Given this list of marker genes Abcc3, Adora1 (adenosine A1 receptor), Slc35d3, Ralbp1, Shoc2, Slc25a54, Abcc2, Abcb1a (ATP-binding cassette, sub-family B member 1A), Abcc4, Lrrc8b, Slc35b4, Slc25a19, Cln3, Slc37a4, Slc35a3, Slc25a25, P2rx7, Calhm1, Scarb1, Slc15a3, Vldlr, Slc5a2, Slc35c2, Slc28a3, Cd47, Slc25a24, Slc50a1, Slc29a1, Slc35d1, Slc46a2, Calhm4, Slc29a3 (solute carrier family 29 (nucleoside transporters), member 3), Guk1, Mfsd2a, Slc35c1, Rft1, Lrrc8d, Adcy10, Calhm6, Slc35b3, Slc35b2, Lrrc8a, Slc25a42, Slc29a2, Slc28a2, Pla2g10, Slc15a2, Slc35d2, Abcc5, Slc29a4, Slc25a17, Slc25a4, Slc19a1, Slc25a26, Slc25a31, Slc5a1, Slc28a2b, Slc25a41, G6pc3, Slc37a1, Spns1, Tmem241, Calhm3, Slc35a1 (NCBI Gene Id 99967, solute carrier family 35 (CMP-sialic acid transporter), member 1), G6pc1, Lrrc8c, Abcc6, Ank, Gjb1 (NCBI Gene Id 236927), Slc25a23, Calhm2, Pltp, Calhm5, Gja1, Slc25a5, Slc15a4, Slc17a9, Slc28a1, Panx1, Slc35a5, Slc37a2, Slc10a7, Slc35a2, Lrrc8e, Slc35b1, Abcg1, Lbp, Psap, Plekha8, here is a description of the gene set: The directed movement of a carbohydrate derivative into, out of or within a cell, or between cells, by means of some agent such as a transporter or pore. studied in species Mus musculus Mouse Gene Set: GOBP_CARBOHYDRATE_DERIVATIVE_TRANSPORT